Given this list of marker genes RNU6-1330P, AGGF1, CRHBP, ATP5PFP4, SNORA50D, TNPO1-DT, GUSBP15, GTF2H2C, GUSBP14, FCHO2, CCNB1, RPL27AP5, SAP18P1, TNPO1, LINC02219 (NCBI Gene Id 102467655), RPS2P24, ALDH7A1P1, GTF2H2, SNORA47, F2RL1, ANKRA2, SNRPCP2, PDE8B, LINC02122, GCNT4, RN7SL616P, TMEM174, OCLNP1, NAIPP4, RNU6-1232P, GUSBP9, LINC01386, GUSBP16, LINC02242 (long intergenic non-protein coding RNA 2242), TAF9, CDH12P3, LINC01385, RNU7-175P, NAIP, FOXD1, RN7SL208P, RNU7-196P, BCL9P1, SV2C, SMN1, YBX1P5, CDH12P1, RPL21P55, LINC02197, SLC30A5, FOXD1-AS1 (FOXD1 antisense RNA 1), UTP15, ENSG00000212249, ARHGEF28, CHCHD2P2, ZBED3, ENSG00000250978, FCHO2-DT, ENSG00000249295, MRPS27, RAD17, SUMO2P4, RN7SL153P, MIR4803, CDH12P2, F2RL2, NSA2, AK6, CTDNEP1P2, ZNF366 (NCBI Gene Id 195826), HEXB, NAIPP1, GUSBP17, HMGCR, SERF1B, GFM2, PDCD5P2, GUSBP3, PMCHL2, IQGAP2, ZBED3-AS1, NDUFB9P1, RPL35AP13, BDP1, LINC02198 (long intergenic non-protein coding RNA 2198), CENPH, SUMO2P5, H2BL1P, CARTPT, BIN2P2, MCCC2, KGD4, SMN2, POC5, MIR4804, SERF1A, ENSG00000251599, NAIPP3, HMGN1P12, CFL1P5, ENSG00000212363, LINC01333, SLC25A5P9, CDK7, ANKRD31 (NCBI Gene Id 256006), ENSG00000304504, SV2C-AS1, RNU6-724P, PIK3R1, FAM169A-AS1, TMEM171, MARVELD2, LINC01331, RNU6-658P, BTF3, NAIPP2, HMGB1P35 (high mobility group box 1 pseudogene 35), HMGN2P4, OCLN, SMN-AS1, FAM169A (NCBI Gene Id 26049), LINC02230, PTCD2, ANKDD1B, FUNDC2P1, CHP1P1, CERT1, RN7SKP251, RN7SL814P (NCBI Gene Id 106481143), CDH12P4, RNU6-680P, CCDC125, ENSG00000250348, GTF2H2B, RNU6ATAC36P, BTF3-DT, RPL7P22, VWA8P1, ENSG00000249713, RPS27P14, RPL7P23, EEF1B2P2, RAP1BL, ENC1, S100Z, F2R, RNA5SP186, GUSBP13, POLK, ARPC1AP3, MAP1B, here is a description of the gene set: Human Gene Set: chr5q13 studied in species Homo sapiens